The following is a description of a gene set: Human Gene Set: GOBP_MITOCHONDRIAL_ELECTRON_TRANSPORT_NADH_TO_UBIQUINONE The transfer of electrons from NADH to ubiquinone that occurs during oxidative phosphorylation. species: Homo sapiens, and this is the list of marker genes: PARK7, NDUFS1, NDUFV3, NDUFAB1, NDUFA4, NDUFB7, NDUFS3, NDUFA9, MIR210, NDUFB9, MT-ND5, NDUFA11, NDUFA2, NDUFC2-KCTD14, NDUFA8, NDUFB6, NDUFB4, NDUFA7, NDUFA10, COQ9, ISCU, NDUFB2, DNAJC15, MT-ND1, PINK1, DLD, NDUFA6 (NADH:ubiquinone oxidoreductase subunit A6), NDUFB8, MT-ND6, NDUFB3, NDUFS5 (NADH:ubiquinone oxidoreductase subunit S5), NDUFA1, NDUFS6, NDUFS8, MT-ND3, MT-ND4L, NDUFB1 (NCBI Gene Id 4707), SNCA (NCBI Gene Id 6622), NDUFA3, MT-ND4, NDUFB10, NDUFC1, NDUFS2, NDUFS7, NDUFV1, NDUFS4, NDUFC2, NDUFB5, NDUFAF1, NDUFV2, NDUFA5, MT-ND2